The following is a description of a gene set: Genes predicted to be targets of miRBase v22 microRNA hsa-miR-488-5p in miRDB v6.0 with MirTarget v4 prediction scores > 80 (high confidence targets). species: Homo sapiens Human Gene Set: MIR488_5P from publication Chen Y, Wang X (PMID 31504780), and this is the list of marker genes: ETV5, CADM3, TASOR, ENAM, SH3GLB2, RETREG1, FANCI, PTGS1, CHMP1B, SKIL, NETO1, CHN2, SCYL2, COL12A1, PSPC1, CDK13, EBF1, SIAH1, RCAN2, ADNP, RAB10, CTCFL, ZC3H14, MEIOC, NOVA1, FAR2, SYCP1, ANKDD1A, ARL6IP1, DIXDC1, CCDC34, CHMP7, CHFR, SNRK, NCOA1, FLRT2 (fibronectin leucine rich transmembrane protein 2), EFCAB11, ADAM28, CAPN2, CLEC4A, GLRB, KLHL4, RNF212, BRINP2, TOPORS, EGLN1, SDR16C5, CLIP4, TYRP1, AGPAT1, CAND1, PXDC1, NBEA, MOBP, H2AZ2, ARFGEF2, ARHGEF28, ARHGEF12, C7orf25, ACTR3, XAF1, MRAS, FAM177A1 (family with sequence similarity 177 member A1), ZYG11B, LIMD2, ELF4, CREBBP, CCDC102B, CREM, PDE12, TCEA1, ATP1A1, PKHD1, FSD1L, LAGE3, ITM2B, KCNH1, LRRC15, MTFMT